The following is a description of a gene set: Reactome Pathway: Sema4D in semaphorin signaling species: Mus musculus electronically inferred by orthology from the curated human pathway This event has been computationally inferred from an event that has been demonstrated in another species.<p>The inference is based on the homology mapping from PANTHER. Briefly, reactions for which all involved PhysicalEntities (in input, output and catalyst) have a mapped orthologue/paralogue (for complexes at least 75% of components must have a mapping) are inferred to the other species. part of: Semaphorin interactions, and this is the list of marker genes: Erbb2, Rras, Sema4d, Rhob, Rnd1, Arhgef12